Given this list of marker genes ENG, BMP10, PITX2, WNT2, PROX1, MYH6, NOG, here is a description of the gene set: Human Gene Set: GOBP_ATRIAL_CARDIAC_MUSCLE_TISSUE_MORPHOGENESIS studied in species Homo sapiens The process in which the anatomical structure of cardiac atrium muscle is generated and organized.